The following is a description of a gene set: studied in species Homo sapiens Aplasia/Hypoplasia of the fibula Absence or underdevelopment of the fibula. Human Gene Set: HP_APLASIA_HYPOPLASIA_OF_THE_FIBULA, and this is the list of marker genes: AFF4, BMPR1B (NCBI Gene Id 658), GDF5, COL11A1 (NCBI Gene Id 317718, collagen type XI alpha 1 chain), EIF4A3, LMBR1, SHOX, INPPL1, SF3B4, ATR, TBX15, GPC6, IFT122, PTH1R, DYNC2H1, CEP120, SLC35D1, SMOC1, FLNA, WNT7A, AMER1, MET, CPLANE1, FZD2, BHLHA9, AFF3, RBM8A, FLNB, INTU, COG4, SOX9